Given this list of marker genes SEMA4F, SEMA6A, SEMA3A, SEMA3D, DPP4, SEMA3G, FLRT2, SEMA4G, FLRT3, SEMA3F, SEMA4A, NRG1, APOA1, SEMA6B, SEMA5B, SEMA3C, SEMA7A, SEMA6D, SEMA3E, SEMA5A, SEMA3B, NRG3, EFNA5, SEMA4B, SEMA4D, SEMA6C, SEMA4C, EPHA7, here is a description of the gene set: Human Gene Set: GOMF_CHEMOREPELLENT_ACTIVITY studied in species Homo sapiens Providing the environmental signal that initiates the directed movement of a motile cell or organism towards a lower concentration of that signal.